Given this list of marker genes Ccr7, Cxcl13, Tmem102, Wnk1, Lgals9, Adam10, Ccr2, Stk39, Xcl1, Tnfsf14, Wnt5a, Adam17, Ccl5, Ccl21a, Oxsr1, Cxcl10, here is a description of the gene set: studied in species Mus musculus Mouse Gene Set: GOBP_REGULATION_OF_T_CELL_CHEMOTAXIS Any process that modulates the rate, frequency or extent of T cell chemotaxis. T cell chemotaxis is the directed movement of a T cell in response to an external stimulus.